The following is a description of a gene set: studied in species Mus musculus Mouse Gene Set: REACTOME_CA2_ACTIVATED_K_CHANNELS Ca2+ activated K+ channels, and this is the list of marker genes: Kcnn1, Kcnn3, Kcnmb2, Kcnmb3 (potassium large conductance calcium-activated channel, subfamily M, beta member 3), Kcnn4, Kcnmb4